Given this list of marker genes SH3TC2, TMEM267, DLG1, DEFB118, POC1B, RALBP1, EXO5, ZBTB41, SETBP1, TPRG1L, SLC9C2, TRPM6, SLC2A13, SEC23A, MMP1, APOBEC3B, PICALM, IGF1R, CMKLR2, ACADSB, HNRNPU, PTPRB, SLMAP, AFF4, CEP170, MAFF, SAMD12, FRA10AC1, PPP1R3A, CROT, CNIH1, SORT1, GLCCI1, MYO19, IKZF5, MAP1B (NCBI Gene Id 4131), MPHOSPH8, BCL2L1, TTI2, RNF128, FER, KBTBD4, RHOB, DMC1, RORA, MEGF10, LRIG1, ABHD17C, LPP, BCLAF3, PCDH9, TPGS2, XPO7, FUT9, NKIRAS1 (NCBI Gene Id 57083), NQO1, ZFP36L1, CEP41, SCAI, HS3ST6, USP22, LARP4B, ANXA7, AGPS, LZTFL1, ARL6IP6, PDE1A, KANK1, CREBRF, SLC2A12, FBXO38, USP18, NEGR1, ITGA2, IRAK1BP1, MAPKAP1, MTPN, WNK1, MSTN, SPATA31A5, SACM1L, KAT6A, FSTL5, ZNF318, AGTR1, PTPRR, MTF1, GOLM2, HIVEP2, LRRC15, RDX, MMD, SCD5, RAVER2 (NCBI Gene Id 89143), CACNA1D, MEIS2, ENKUR, FDCSP, SPATA31C1, LEKR1, SLC46A3, SPATA31A6, NIPSNAP2, RASA1 (RAS p21 protein activator 1), SERTAD3, KPRP, TFB1M, SIRT5, PDE1C, MORC3, RMDN2, FBXO30 (NCBI Gene Id 84085), LYN, SPATA31A7, DGKI, PHTF2, DGKH, SCN1A, STX7, VBP1, NREP (neuronal regeneration related protein), COL19A1, GMEB1, PAQR9, SPATA31A3, IL21, ARHGEF28, SLC6A14, SACS, MSRB2, TMEM64, here is a description of the gene set: Human Gene Set: MIR6833_5P studied in species Homo sapiens from publication Chen Y, Wang X (PMID 31504780) Genes predicted to be targets of miRBase v22 microRNA hsa-miR-6833-5p in miRDB v6.0 with MirTarget v4 prediction scores > 80 (high confidence targets).